The following is a description of a gene set: Genes up-regulated in erythroid lineage cells by RUNX1-RUNX1T1 fusion. from publication Tonks A, Pearn L, Musson M, Gilkes A, Mills KI, Burnett AK, Darley RL (PMID 17898786) The t(8;21)(q22;q22) occurs frequently in acute myelogenous leukaemia and gives rise to the transcription factor fusion protein, RUNX1-RUNX1T1 (also known as AML1-ETO). To identify the genes dysregulated by the aberrant transcriptional activity of RUNX1-RUNX1T1, we used microarrays to determine the effect of this mutation on gene expression in human progenitor cells and during subsequent development. Gene signatures of these developmental subsets were very dissimilar indicating that effects of RUNX1-RUNX1T1 are highly context dependent. We focused on gene changes associated with the granulocytic lineage and identified a clinically relevant subset of these by comparison with 235 leukaemia patient transcriptional signatures. We confirmed the overexpression of a number of significant genes (Sox4, IL-17BR, CD200 and gamma-catenin). Further, we show that overexpression of CD200 and gamma-catenin is also associated with the inv(16) abnormality which like RUNX1-RUNX1T1 disrupts core binding factor activity. We investigated the functional significance of CD200 and gamma-catenin overexpression in normal human progenitor cells. The effect of IL17 on growth was also assessed. Individually, none of these changes were sufficient to recapitulate the effects of RUNX1-RUNX1T1 on normal development. These data provide the most comprehensive and pertinent assessment of the effect of RUNX1-RUNX1T1 on gene expression and demonstrate the highly context-dependent effects of this fusion gene. Human Gene Set: TONKS_TARGETS_OF_RUNX1_RUNX1T1_FUSION_ERYTHROCYTE_UP studied in species Homo sapiens, and this is the list of marker genes: HOMER3, LILRA1, RHOQ, SPTAN1, GPNMB, GBP2, AP1S1, LRP3, GIPC1, SIRPAP1, DDR1, SLC7A11 (solute carrier family 7 member 11), DNAJB2, SLC1A3, HSPB1, PNRC1, TIAM1, CPD, TCF7L2, TMEM176A (transmembrane protein 176A), IFI16, BAALC, MEAK7, CXCL5, PXDN, NQO1, KLF2, BTG1, RUBCNL, TLR7, QPRT, TREM1, EEF1A2, CPM, PLTP, P2RX4, KLF6, PLPPR3, NRCAM, IFI6, TFPI2, FCGR1A, C3AR1, RASGRP1 (RAS guanyl releasing protein 1), JUN, DKK2, NUPR1, PPARD, SLC2A5, SELENOP, SLC5A3 (NCBI Gene Id 6526), JAG2, FNDC3B, TM4SF1, IL1RAP, LAIR1, IFI44, NDRG1, CYP1A1, ARAP3, CRHBP, VCAN, GPR20, UPP1, MALL, ACSL1, TLR2, TNNT1, ATXN1, DHRS9, PTP4A3, STIMATE, DNASE2, ADCY9 (adenylate cyclase 9), TMEM176B (transmembrane protein 176B), SSBP2, GDF15, NAP1L1, FUT4, NTS, UCHL1, MYOF, SCG5, EXT1, PLK2, NETO2, ZNF217, HADHAP1, CLEC5A, PIK3C2B, EMP1, MAPK3, ARL4A, STAT1, ENPP2, TUBB6, CD79B, ADAMTSL4, SLCO4A1, PLAT, APP, ALDH1A2, SERPINA1, TPK1, ACVR1B, SLAMF8, CREM, BCL2A1, IL1RN, CD1D, HOXA9, NRIP1, MAN1A1, CD180, RRAGD, SOX4, H2AC18, ETNK1, MAF, FABP3, HERC5, CTSL, PAPSS2, ARMCX2, VSIG4, LAMC1, CCL7, DUSP6, MAGED2, TRIB3, VAT1, OLR1 (oxidized low density lipoprotein receptor 1), FCAR, ELANE, IRAK3, AMIGO2, ERG, TNFRSF21, ECM1, LILRB1, SPATS2L, CD200, ANXA2P3, DENND5A, JAM3, PDGFA, IL17RB, SOCS3, ANXA2, RBPMS (NCBI Gene Id 11030), TASL, ID1, LILRA2, COL1A2, CH25H, SLC15A3, LPL, PALM, CD163